The following is a description of a gene set: studied in species Homo sapiens Human Gene Set: WHN_B Genes having at least one occurrence of the motif ANNGACGCTNN in the regions spanning 4 kb centered on their transcription starting sites. This matches the FOXN1 transcription factor binding site V$WHN_B (v7.4 TRANSFAC)., and this is the list of marker genes: NRK, GRIA3, ZBTB18, ZBTB37 (NCBI Gene Id 84614), GRIN2B, PPARGC1A, ENSG00000204117, PMP22, HAPLN1, RPL41, JUNB, ONECUT1, MYH13, ZNF385A, TOB1, TBC1D32 (TBC1 domain family member 32), WNT9B, H2AZ1, ALK, DDX5, POU3F3, LAMTOR1, SYT4, KLF2, VAX1, HAUS4, CTCF, SLC20A1, JUP, WNT3, RBM24, JARID2, PTMA, INSM1, SYNJ1, OPHN1, HOXC11, CAMK4, CRYL1, LEF1, SND1, RFX4, SIX1 (NCBI Gene Id 6495), SLC30A7, SPRY2, DDX17 (NCBI Gene Id 10521), EGR3, ARHGAP36, ELOVL6, TAF5, ZBTB11, ANKS1B, ZBTB4, CCAR1, PCDHGA2, SRRM3 (NCBI Gene Id 222183), SLC25A4, AZIN1, BHLHE40, NSF, HOXA3, STC2, HOXA7, SNX9, GALK2, ID2, KCTD4, PRSS16, DUSP14, ATG16L1, MIDEAS, YTHDF2, GSKIP (NCBI Gene Id 51527), HSPA14, MTMR4, SF3B1, NRG1, NPR3, FOXA1, PCGF1, RSBN1, ARID4B, ACO2 (aconitase 2), MLLT11, MRPL12, DLL4, AMD1, MBNL1, AKIRIN2, NUDT11, IRX5, NAT8L, TSC22D3, GABRG2, CXADR, METTL6, PNPLA6, CAPN12, NR4A3, CFAP299, SENP2, RGL1, RNF6, THRA, PFN2, SLC25A40, FOXO4, CEP95, GPR173, MIB1, CDC42SE1, DHX30, SSB, DNAH9, COL4A6, POLR2A, HTN1, ZNF524, PRDM12, PRDM10 (NCBI Gene Id 56980), TBX6, SIRPA, DBF4, GGPS1, EIF4A1, MYO1E, UBR5, HOXB9, STAG2, KIAA0825, HSPD1, PAX3, WNT1, COPS2, ARMC8, LMO3, ZNF362, SIK1, HYDIN, CCPG1, CCDC140, PHF21B, RPRD2, SUMO1, NFKB2, MYH2, HNRNPH3, SLITRK5, GJC1, HOXA9, RNF43, CSDE1, TOB2, TMEM203, ANKRD17, ERLIN2, TFAP4, ICA1, FMC1, STT3B, PITPNA, PPP3CA, KCNS3, CREBRF, RO60, HOXC6 (NCBI Gene Id 3223), TOP1, EBF1, NEUROG3, ZNF644, DLG5, ZCCHC9, CDC26, OTUD5, TMEM86A, HPCAL1, SAXO4, COL4A5 (collagen type IV alpha 5 chain), ESRRG, NOLC1, SDCBP2, JAG1, NMNAT2, ANKH, UCHL5, HOXB8, ERLIN1, SUPT16H, CDC14B, PCDH7, FAP, ZBTB12, SH3BP5L, JUN (NCBI Gene Id 3725), SALL1, LRP1B, HSPE1, WNK2, NUDT10, VEZF1, ZEB2, EFNB1, NUDT21, NR2E1, EAF1, JPH2, NIN, ARFGEF1, CHST11, PRPF4, EML2, SLC35E1, ZC3H10, TBX3, TAC1, ARPC5, GRIN2A, DOLK, PAPPA, LAPTM4A, BTRC, FAM174A, FOXP2, ARIH1, H3-3B, PHF5A, DNAJB4, MACO1, POU3F4, CNOT11, ANKRD13B, ZNF768, ELAVL3, EXTL2, HERC1, FIZ1, KLHL13, BBS5, TOMM40, SOX3, SFN, FSTL5, SREK1, CALM2, SKIDA1, NKX2-2, HDAC4, TRIB1, NF1, RAB11A (NCBI Gene Id 8766), POU4F1, JADE2, NDOR1, HSP90B1, GREB1L, ADRA2C, CEP164, ANGPTL5, SNCB, BANP, BDNF